The following is a description of a gene set: Amplified MYC to cell cycle G1/S. Pathway ID: N00089. Pathway type: Variant. Pathway class: nt06267 Small cell lung cancer. Human Gene Set: KEGG_MEDICUS_VARIANT_AMPLIFIED_MYC_TO_CELL_CYCLE_G1_S species: Homo sapiens Pathway Definition from KEGG: (MYC*+MAX) => (CCND+CDK4/6) -> RB1 // E2F, and this is the list of marker genes: E2F2, MAX, MYC, E2F3, CCND3, CCND1, CDK6, E2F1, RB1, CDK4, CCND2